The following is a description of a gene set: Marker genes curated from the annotated cluster as represented in the Descartes Human Gene Expression During Development database. from publication Cao J, O'Day DR, Pliner HA, Kingsley PD, Deng M, Daza RM, Zager MA, Aldinger KA, Blecher-Gonen R, Zhang F, Spielmann M, Palis J, Doherty D, Steemers FJ, Glass IA, Trapnell C, Shendure J (PMID 33184181) The gene expression program underlying the specification of human cell types is of fundamental interest. The study authors generated human cell atlases of gene expression and chromatin accessibility in fetal tissues. For gene expression, the study authors applied three-level combinatorial indexing to >110 samples representing 15 organs, ultimately profiling ~4 million single cells. The study authors leveraged the literature and other atlases to identify and annotate hundreds of cell types and subtypes, both within and across tissues. Our analyses focused on organ-specific specializations of broadly distributed cell types (such as blood, endothelial, and epithelial), sites of fetal erythropoiesis (which notably included the adrenal gland), and integration with mouse developmental atlases (such as conserved specification of blood cells). These data represent a rich resource for the exploration of in vivo human gene expression in diverse tissues and cell types. species: Homo sapiens Human Gene Set: DESCARTES_FETAL_LIVER_VASCULAR_ENDOTHELIAL_CELLS, and this is the list of marker genes: CLEC4M, LINC03002, ENSG00000253281, FCN3, EDN1 (endothelin 1), NTN5, HSPG2, FLT4, TMC7 (NCBI Gene Id 79905), LINC02984, DLL4, TM4SF18, FGF23, ENSG00000259072, NOVA2, BMX, RFPL1, F8, TSPAN7, STAB1, EXOC3L1, SH3RF3, PLPP3, RNU6-501P, CLEC3B, FEZ1, TINAGL1, GNA14, KIF17, ECSCR, EEF1A1P31, PTCHD4, IRS3P, CLEC14A (C-type lectin domain containing 14A), DKK2, CPXM2, PRUNE2, DUSP5, GABRG3, PCA3, TAMALIN, C2CD4D-AS1, SYCP1, TMEM233, RASIP1, SLCO5A1, EGFL7, PLK2, NTS, ENSG00000233251, CNTNAP3B, SLC19A4P, GPR182, LINC01541 (NCBI Gene Id 100509337, long intergenic non-protein coding RNA 1541), NHSL2, LINC01545, ASB11 (ankyrin repeat and SOCS box containing 11), PDE2A, HECW2, SOX7-AS1, LINC01170, IL13RA2, DIPK2B, NOSTRIN, PTPRB, GALNT18, NOS3, PVALB, ADM, BMPER, ARHGEF15 (NCBI Gene Id 80081), OLFM1, NETO2, TP53I11, MYRIP, CHRNA7, CT69, ENSG00000212594, DCST2, SMAD9, BTNL9, IL33, ADGRL4, DNASE1L3, CRHBP, OIT3, SOX17 (NCBI Gene Id 64321), LRRC66, LDB2, CIMAP1D, LRIG3, LRRIQ4, PTPRN2, THSD1, KLF8, EEIG1, MMRN2, SPATA18, ACSM1, BMP2 (bone morphogenetic protein 2), NXF3, CPNE5, BRINP1, WWTR1-IT1, LEMD1-AS1, TSPAN18, PITPNM3, RP1, RTN4RL1 (reticulon 4 receptor like 1), NUDT10 (NCBI Gene Id 170685), CFAP206, NOTCH4, TRPM6, CLEC4G (C-type lectin domain family 4 member G), ENSG00000272789 (novel transcript, antisense to MYO7B), EMCN, STAB2, ADGRF5, CLEC4GP1, CRACR2B, ENSG00000187185, VIP, GNA14-AS1, PCAT19, SLCO2A1, KIF19, FCN2, REN, KLHL4, HSPA12B, NTN4, ACP5, MAN1C1, LHFPL2, RASSF9, ZEB1-AS1, RAMP3, JAM2, LINC02005, CCM2L, ENSG00000243008, AFAP1L1, KANK3, KDR (kinase insert domain receptor), FLT1, C2CD4B, ADCY4